Given this list of marker genes Mecp2, Nrxn2, Hoxd9, Slc1a2, Sez6l (seizure related 6 homolog like), Shank2, Kcnma1 (NCBI Gene Id 70528), Idua, a, Bbs2, Pax5 (paired box 5), Fgf14, Scn1a, Grm7, Cstb, Fgf12, Ghrl, Tbce, Mapt, Otog, Drd2, Fadd, Tshr, Grin2d, Rnf180, Slitrk1, Trh, Hipk2, Homer2, Abl2, Nlgn3, Agtpbp1, Npy, Oprk1, Btbd9, Gabrg2, Crebbp, Pcdh15, Kalrn (NCBI Gene Id 72378), Chrnb4, Snca, Gpr39, Mafg, Unc79, Ppara, Bdnf, Oprm1, Hexa, Npc1, Alk, Gigyf2, Ngf (NCBI Gene Id 18049), Tsx, Fgfbp3, Ghsr, Gip, Ctns, Kcnj10, Sncg, Htr2c, Id2, Nr4a3, Crhr1, Oxr1, Arrb2, Uchl1, Zic1, Enpp1, Pten, Dmrt3, Sdk1, Bbs4, Atxn1, Cnp, Sez6, Epha4 (Eph receptor A4), Sptbn2, Pum1, Abhd12, Ntan1, Slc7a11, Pcdh17, Shank1, Hoxb8, Pbx3, Crhbp, Cln8, Htra2, Sptbn4, Ntf5, Gbx1, Foxa2, Atp6v1b1, Prex2, Pmp22, Aldh2, Slitrk5, Lgi4, Drd1, Park7, Chl1, Chrna5 (NCBI Gene Id 11439), Cdh23, Atp1a3, Cxcl12, Efnb3, Cend1, Cntn2, Ndufs4, Pafah1b1, Chd7, Chrna3, Nlgn2, Naglu, Htr2a, Nrxn1, Chat, Hoxd10, Klhl1, Dab1, Fosb, Cntnap2, Bbs1, Cacnb4, Oprd1, Homer1, Agrp, Ulk4, Glra1, Chrnb2, Tsc1, Cacna1c, Glrb, Mir96, Wdr47, Inpp5f, Zfhx2, Cacna1a, Parp1, Slitrk6, Rnf170, Prkn, Septin5, Adam2, Cdk5, Usp46, Trmt1l, Ppt1, Fkrp, Fxn, Ntsr1, Grik1, Chrnb1, Nr4a2, Ppp1r1b, Sez6l2, Htr1a, App, Vps13a, En1, Slc6a4, Clcn3 (NCBI Gene Id 12725), Adam22, Nrxn3, Met, Lep, Adra1b, Nos1, Adh1, Grin1, Bc1, Slc10a4, Chrna4, Mir23a, Zmpste24, Ncstn, Drd3, Dmbx1, Slc1a1, Atp1a2, Shank3, Chrna6, Grm2, Chrna7, Atg7, Tpgs1, Tuba1a, Drd4, Arcn1, Uchl3, Ehmt2, Tmod1, Dbh, Ccnd2, Fgf2, Axin1, Eps8, Cartpt (NCBI Gene Id 27220), Scn8a, here is a description of the gene set: Mouse Gene Set: GOBP_ADULT_BEHAVIOR species: Mus musculus Behavior in a fully developed and mature organism.